The following is a description of a gene set: studied in species Mus musculus A ribonucleoprotein complex that contains the small ribosomal subunit, a translation initiation ternary complex (i.e. an initiator tRNA, GTP, and an IF2 or eIF2 complex), and an mRNA. Mouse Gene Set: GOCC_CYTOSOLIC_TRANSLATION_PREINITIATION_COMPLEX, and this is the list of marker genes: Eif3i, Eif3a, Eif3j1, Eif1b, Eif3h, Eif3b, Eif3l, Eif3m, Eif1a, Eif3j2, Eif3e, Eif3d, Eif2s1, Eif3k, Eif1, Eif3c, Eif3f, Dhx29, Eif1ax, Eif3g